Given this list of marker genes CCNA2, PRDM5, ADAD1, ANXA5, KIAA1191P1, NDNF, BLTP1, TRPC3, LTV1P1, SMIM43, BBS12, PP12613, SETP12, MAD2L1, BBS7-DT, CETN4P, MAD2L1-DT, BBS7, IL21, ENSG00000296649, RN7SKP137, RNU6-948P, EXOSC9 (NCBI Gene Id 5393), SAR1AP3, QRFPR, TNIP3, IL21-AS1, IL2, RN7SL335P, LINC02502, NDNF-AS1, TUBB4BP5, RNU6-550P, here is a description of the gene set: studied in species Homo sapiens Human Gene Set: chr4q27